The following is a description of a gene set: Mouse Gene Set: GOMF_STRUCTURAL_CONSTITUENT_OF_PRESYNAPTIC_ACTIVE_ZONE The action of a molecule that contributes to the structural integrity of a presynaptic active zone. species: Mus musculus, and this is the list of marker genes: Rimbp2, Rims2, Ctbp2, Erc1, Pclo, Rims1, Rims3, Erc2, Bsn